Given this list of marker genes Brf1, Snapc4, Gtf3c1, Tbp, Gtf3a, Gtf3c4, Snapc5, Gtf3c5, here is a description of the gene set: species: Mus musculus A general transcription initiation factor activity that contributes to transcription start site selection and transcription initiation of genes transcribed by RNA polymerase III. Factors required for RNA polymerase III transcription initiation include TFIIIA, TFIIIB and TFIIIC. RNA polymerase III transcribes genes encoding short RNAs, including tRNAs, 5S rRNA, U6 snRNA, the short ncRNA component of RNases P, the mitochondrial RNA processing (MRP) RNA, the signal recognition particle SRP RNA, and in higher eukaryotes a number of micro and other small RNAs, though there is some variability across species as to whether a given small noncoding RNA is transcribed by RNA polymerase II or RNA polymerase III. Mouse Gene Set: GOMF_RNA_POLYMERASE_III_GENERAL_TRANSCRIPTION_INITIATION_FACTOR_ACTIVITY